The following is a description of a gene set: studied in species Mus musculus Mouse Gene Set: GOBP_MIDBRAIN_DEVELOPMENT The process whose specific outcome is the progression of the midbrain over time, from its formation to the mature structure. The midbrain is the middle division of the three primary divisions of the developing chordate brain or the corresponding part of the adult brain (in vertebrates, includes a ventral part containing the cerebral peduncles and a dorsal tectum containing the corpora quadrigemina and that surrounds the aqueduct of Sylvius connecting the third and fourth ventricles)., and this is the list of marker genes: Barhl1, Wnt3, Pitx3, Fgfr3, Wnt2, Fzd3, Lmx1b, Gdf7, Uqcrq, Otx2, Wnt5a, Otx1, Fgf2, Kdm2b, Phox2a, Dvl3, Ryk, Smad9, Ndst1, Tfap2d, Fgfr1, Kat2a, Ctnnb1, Fgfr2, Sfrp1, Smad1, Fzd6, Uchl5, Kdm7a, Aplp2, Wnt9b, Wnt1, Hes1, En1, Sos1 (NCBI Gene Id 70778), Dkk1, Msx1, Dlg5, Hes3, Shh, Foxb1, Csnk1d (casein kinase 1, delta, NCBI Gene Id 71708), Lrp6, Wnt3a, Wls, Rac1, Tal2, Cxcr2, En2, Sfrp2, Lmx1a